Given this list of marker genes SPTAN1, CLTC, SRGAP2, PEAK1, ARHGEF7, WWP2, NCK2, WDR6, ARHGAP31, PIK3R1, ARHGEF6, IQGAP1, PAK4, GIT2, DEPDC1B, ITSN2, PTK2B, PAK3, USP9X, TXNL1, PAK1, DLG5, ARHGAP30, GRB2, STAM2, VANGL1, MYO6, NCK1, SPTBN1 (NCBI Gene Id 91654), EPHA2, PARD6A, HGS, GIT1, DST, RHOU, SRC, PIK3R2, CDC42, STAM, PAK2, here is a description of the gene set: Reactome Pathway: RHOU GTPase cycle RHO GTPase RHOU (Wrch-1) possesses a high intrinsic guanine nucleotide exchange activity and is constitutively present in the active GTP-bound state in the absence of guanine nucleotide exchange factors (GEFs). RHOU does not possess a GTPase activity. RHOU has been reported to interact with some GTPase activator proteins (GAPs), which may serve as effectors that enable cross-talk with other RHO GTPases. RHOU was shown to regulate cytoskeletal dynamics, cell migration and adhesion. RHOU is expressed during embryonic development and regulates cardiac and intestinal development. RHOU activates JNK and AKT signaling during cell migration.<br>For review, please refer to Faure and Fort 2015, and Hodge and Ridley 2020. studied in species Homo sapiens part of: RHO GTPase cycle